The following is a description of a gene set: studied in species Mus musculus Mouse Gene Set: DESCARTES_ORGANOGENESIS_GRANULE_NEURONS Mouse Organogenesis Cell Atlas (MOCA) DE_gene_main_cluster.csv, fold.change>=1.5, qval<0.05, pval<0.05 from publication Cao J, Spielmann M, Qiu X, Huang X, Ibrahim DM, Hill AJ, Zhang F, Mundlos S, Christiansen L, Steemers FJ, Trapnell C, Shendure J (PMID 30787437), and this is the list of marker genes: Ppp2r2b, Thtpa (thiamine triphosphatase), Gm26604, Itprid1, 6030443J06Rik, Epha5, Gm29455, Sorbs2, Epha3, 6530403H02Rik, C230057M02Rik, Tmod4, Kash5, Eomes, Nos1, Tbr1, Abcc8, Ntng2, Kif21b, Nfib, Bhlhe22, E130114P18Rik, Cngb1, Vps37d, Hs3st1, Mpped1, Carmil3, 2600014E21Rik, 2900079G21Rik, Slc17a7, Prdm8, Zfhx2os, A330093E20Rik, Lrfn5, Cnr1, Kcnj11, Neurod6, Cdh13, Rasgrp1, Rapgef4os1, Camkv, Pgap1, Kcnh5, Frrs1l, Neurod2, Kctd6, Ccser1, Tiam2, Gm33280, Kcng1, Sez6, A730020E08Rik, Tmem178, 3110062G12Rik, Plxna4, 6530402F18Rik